Given this list of marker genes GNB4, TMEM263, ARG2, SPATA32, ATL2, TSC22D3, CHMP1B, HOXA4, NANS, PSENEN, UCN (urocortin), VIP, DGUOK, GLI1, DNTTIP1, CSF2, FAM78A, KCNA5, AFF4, HAND1, GASAL1, MROH5, HOXB9, RUNDC3A, CSF3, CUTA, MBD6, CBX8 (chromobox 8), OGDH, IRF2BPL, NDP, HSP90AB1, HTR2C, SPATA18, RRM2B, CCN4, USP48, AREG, NRF1, LOXL3, ZWILCH, GDNF, DOK1, TGIF2, AFF2, SPMIP5, CORO6, SST, ITK, PCSK1, PDE4D, SPRED2, STAT6, IKBKB, PFAS, TFE3, CNN3, HABP4, CPNE1, GPM6B, EIF4A2 (NCBI Gene Id 63124, eukaryotic translation initiation factor 4A2), SMAD6, TNFRSF12A, MAPK10, SLC18A2, RPL4, CLDN7, TPM4, AKIRIN1, TMEM86A, CDC42, NTRK2, FAM131A, LHX1, SYT13, CYLD, ESRRG, RAI1, ELOVL5, NEUROD6, MAFF, SPATC1, SULT4A1, RNF148, PDZD8, PDE1A, ZFAND5, ZBTB18 (zinc finger and BTB domain containing 18), SRSF6, TAMALIN, TOP1, LMCD1 (NCBI Gene Id 29995), SCP2D1, KCNA6, PRDM12, COQ10A, PPARD, HOXB1, FOS, BNIP3L, YPEL4, TH, HAS1, SUV39H2, SIDT2, KCTD8, MBNL2, YWHAZ, NRXN1, RNPS1, BABAM2, ELL2, TMEM147, FOXD3, C11orf87, HSD11B1, RAB25, RBKS, TBC1D23, OSBPL9, LMO4, IRX4, CREM, ANGPT1, NFIL3, HHIP, GSE1, SOX11, RPL23A, ST20-AS1, SEC23A, DYRK3, ISL1, NR2E1, PAFAH1B1, SRRM4, RET, SLC38A1, PTPRU, CTC1, GEM, FOSB, NOVA1, COPB1, RNF44, ASPHD1, PPARGC1B, KLF9, AQP7, CCNI, KCNIP2, ADARB2, BSND, ERC1, IGFLR1, PCK1, UBE2H, NR6A1, CALD1, PARD6A, C1orf35, KRT33A, MAP1LC3A, ERF, TRIB1, KCNMB3, FGF6, MCAM, NOVA2, EEF2, ADAMTS3, HOXC10 (homeobox C10), TSPYL5, SDHB, PPM1J, CDX4, OSR1, PER1, EIF4A1, HS3ST2, CDX2, CD2AP, SIK1, ID1, DUSP3 (dual specificity phosphatase 3), GK, THRA, NOL4, FLT1, GABRG2, KLHL22 (kelch like family member 22), PLEKHA1, MAGED2, IVNS1ABP, TRIM39, NEDD1, SUMO4, PDP1, YEATS2, PAK1, FBXO33, ATP6V0C, WFDC3, SIK2, U2AF1L4, JUND, CFL2, EHD1, NCALD, MLLT6 (MLLT6, PHD finger containing), LAYN, CREB3L2, SNAP25, FOXP1, PAX1, TSC22D2, CENPE, CACNA1G, CHGB, SCAMP5, FBXW11, PDGFA, DAAM2, PPP2R5C, DDIT3, CD37, STC2, LDHA, TAOK2, MAF, VGF, IRX6, SCG2, SPATA20, COL1A1, DLG2, CCND1, HS3ST3A1, here is a description of the gene set: Genes having at least one occurrence of the motif CYYTGACGTCA in the regions spanning 4 kb centered on their transcription starting sites. This matches the ATF1 transcription factor binding site V$ATF1_Q6 (v7.4 TRANSFAC). Human Gene Set: ATF1_Q6 species: Homo sapiens